The following is a description of a gene set: species: Homo sapiens Human Gene Set: HP_NATAL_TOOTH A tooth present at birth or erupting within the first month of life. Natal tooth, and this is the list of marker genes: C2CD3, EVC2, KDM6A, DSP, LMNA, KRT17, DPH1, POLR3B (NCBI Gene Id 55703), FGFR2, CEP120, EHMT1, SPECC1L, EVC, KDF1, KRT6B, GTF2H5, INTU, CHD6, AMER1, CREBBP, KRT6A, VARS1, ZMPSTE24, MID1, POLR3A, NEK1, PTH1R, GLI3, MKS1, CILK1, KRT16, BCL11B, JUP, EP300, FAM20C, KMT2C, KMT2D, FLNA